The following is a description of a gene set: Genes down-regulated in comparison of NK cells versus NKT cells. studied in species Homo sapiens Each fraction of mouse hematopoietic cells was purified by cell sorting from bone marrow of 8-week-old C57BL/6 mice, and its gene expression was analyzed. Human Gene Set: GSE27786_NKCELL_VS_NKTCELL_DN from publication Konuma T, Nakamura S, Miyagi S, Negishi M, Chiba T, Oguro H, Yuan J, Mochizuki-Kashio M, Ichikawa H, Miyoshi H, Vidal M, Iwama A (PMID 21540074), and this is the list of marker genes: MZT2B, EEF1D, ADAMTS16, ANTXR2, FAM8A1, MLLT6, MRI1, RMND5B, NTRK3, EPB41L3, AFP, CXXC5 (NCBI Gene Id 51523), TMEM104, GABRR2, GPR183, DMRT3, DNAJC1, NSMCE1, CRACD, FXN, MRPS6, MIF, ANTKMT, IL20RA, G2E3, KRT27 (keratin 27, NCBI Gene Id 342574), FOCAD, MAPK8IP2, MTHFD1, ARMC7, INSM1, TRIM37, SMC4, SIKE1, TBCEL, NOB1, UBXN11, PDE1A, CD38, SLC20A1, SESN3, MEF2B, C21orf58, DNM1L, EARS2, PIWIL1, RGS8, NDUFA12, MFN2, URI1, HACD3, FSTL1, C22orf39, CCDC191, TBRG1, CFL1, PCNT, ERICH2, MBOAT1, EREG (NCBI Gene Id 2069), CD226, PM20D1, NR1I2, MFHAS1, CLEC2L, SV2C, TEX47, SEPTIN1, NSUN2, NLRC5, VWCE, DNAH8, HMGXB3, CENPV, SLC25A3, PHGDH, ZNF697, PPCS, NGFR, TMEM200A, C1orf56 (chromosome 1 open reading frame 56), CD247, RRP15, PPM1J, RPP14, TFAP4, PPM1B, SDHA, KIF27, PRKAR2A, EIF3G, ZNF251, DCTN6, PDK1, POLE, CYP4F2, TNFRSF18, TMEM128, KCTD15, FAM133B, TCF7, TMEM177, DTNBP1, CDH10, SHMT1, RNF14, PDLIM2, ATP5F1A, AKAP1, DHX33, RRS1, RRP9, POLR1B, IKZF1, MSH2, A1CF, ZNF622, SLC39A14, TGIF2, ZEB1, METTL17, GMDS, ZFP2, C11orf52, TMEM131L, FGD5, ADRA2C, LRRC28, DGKI, CDK5RAP2 (CDK5 regulatory subunit associated protein 2), USP7, ARMCX4, CFAP251 (cilia and flagella associated protein 251), HK1, ETNK1, FAM162A, HOXD9, ADI1, F2R, STON1, CAVIN4, POLR3E, TAS1R2, EMX2, THEMIS, LANCL1, ARHGEF4, ARL2BP, ANKRD40, CRTAM, EXOC4, LONRF3, HSPB1, IPO8, RPL36, CMSS1, PDCD2, ATOH8, PPP5C, TNFSF8, ZNF512B, GPR15, MYCT1, TXNDC2, SLC51A, EIF3B, ZNF48, ATP1B1, CCDC82, LEPR, MAGEB5, HAS1, NOL9, PES1, NOP56 (NOP56 ribonucleoprotein), LINC00511, UBR1, TNRC6C, TTC28, CIPC, EIF3I, ARB2A, TP53, TYSND1, NUDT6, VIRMA, SMG1, CHD3, ZC3H4, REV1, SCAF1, WDR43, RCBTB1, MED12, SLC5A6, PLAA, TEX13B, NLK, WDR6